Given this list of marker genes Mrpl48, Nptxr, Yif1a, Cacng2, Scamp5, Rwdd2b, Acsl6, Glra1, Ogdhl, Tbx3os1, Cyb5r4, Scg2, Schip1, Meis3, Mir7b, Gprin1, Bdnf, Rbm25, Htr1a, Ric8b, Fbll1, Scn2a, Mapk8ip2, Cadps, Cacng3, here is a description of the gene set: from publication Yevshin I, Sharipov R, Kolmykov S, Kondrakhin Y, Kolpakov F (PMID 30445619) studied in species Mus musculus Genes containing one or more binding sites for (Pitx2) in their promoter regions (TSS -1000,+100 bp) as identified by GTRD version 20.06 ChIP-seq harmonization. Mouse Gene Set: PITX2_TARGET_GENES